Given this list of marker genes SCO2, TSEN2, MTPAP (NCBI Gene Id 55149), TSEN34, TSEN15 (tRNA splicing endonuclease subunit 15), SPG7, VPS37A, TSEN54, SEPSECS, CLDN11 (NCBI Gene Id 5010), here is a description of the gene set: species: Homo sapiens Increased muscle tone observed in the arms of the affected person. Human Gene Set: HP_UPPER_LIMB_HYPERTONIA Upper limb hypertonia